The following is a description of a gene set: Mouse Gene Set: GOBP_SOMATOTROPIN_SECRETING_CELL_DIFFERENTIATION The process in which a relatively unspecialized cell acquires specialized structural and/or functional features of a somatotropin secreting cell. A somatotropin secreting cell is an acidophilic cell of the anterior pituitary that produces growth hormone, somatotropin. species: Mus musculus, and this is the list of marker genes: Wnt4, Prop1, Ghrhr, Pou1f1, Lhx3